Given this list of marker genes IL13, CD300LF, ALOX15, IL13RA2 (NCBI Gene Id 3598), CCL11, SHPK, FOSL2, here is a description of the gene set: studied in species Homo sapiens Any process that results in a change in state or activity of a cell or an organism (in terms of movement, secretion, enzyme production, gene expression, etc.) as a result of an interleukin-13 stimulus. Human Gene Set: GOBP_RESPONSE_TO_INTERLEUKIN_13